The following is a description of a gene set: studied in species Homo sapiens Reactome Pathway: Defective PAPSS2 causes SEMD-PA part of: Diseases associated with glycosaminoglycan metabolism Defects in PAPSS2 cause spondyloepimetaphyseal dysplasia Pakistani type (SEMD-PA; MIM:612847), a bone disease characterized by epiphyseal dysplasia with mild metaphyseal abnormalities. Clinical features include short stature from birth, short and bowed lower limbs, mild brachydactyly, kyphoscoliosis, abnormal gait and enlarged knee joints. Some patients may manifest premature pubarche and hyperandrogenism., and this is the list of marker genes: PAPSS2